The following is a description of a gene set: Human Gene Set: GSE13484_12H_VS_3H_YF17D_VACCINE_STIM_PBMC_UP species: Homo sapiens from publication Querec TD, Akondy RS, Lee EK, Cao W, Nakaya HI, Teuwen D, Pirani A, Gernert K, Deng J, Marzolf B, Kennedy K, Wu H, Bennouna S, Oluoch H, Miller J, Vencio RZ, Mulligan M, Aderem A, Ahmed R, Pulendran B (PMID 19029902) Genes up-regulated in comparison of peripheral blood mononuclear cells (PBMC) cultured with YF17D vaccine for 12 h versus PBMC cultured for 3 h. The immune responses generated by YF-17D by profiling genes in PBMCs from 2 donors cultured with YF-17D vaccine were accessed after 3 and 12 hours., and this is the list of marker genes: CCL8, IFI44L (NCBI Gene Id 10964, interferon induced protein 44 like), LSM6, LHFPL2, XYLT1, TRAPPC3, TPP1, ZBTB14, SELENOT, ATP5F1E, HTRA2, MYO1F, SOS1, MAVS (mitochondrial antiviral signaling protein), TMEM187, LYST, ANP32B, RASSF4, LGALS3, CPM, MEGF9, LIMK2, MYO1B, ZFPL1, LRP12, CYBC1, KIF1B, WDR12, CALCRL, CERS2, PLAT, TGFA, NSD2, ACSM3, SLC46A3, TBC1D2, CHCHD3, ADPRH, ZNF529, RCBTB2 (NCBI Gene Id 1102), NCOA4, OAZ2, AP1AR, IDH1, TRMT2A, UTP14C, CDC42EP2, AKR1B1, COIL, PPP1R3D, GRIA2 (NCBI Gene Id 2891), DCUN1D4, RSRP1, BSCL2, ATRX, RIDA, ZNF280D, SEC22B, SNRNP25, GFOD3P, RENBP, PAPSS1, ADAP2, PGS1, POLG2, BORA, SERPINB7 (NCBI Gene Id 8710), CRIPT, DNMT1, MGLL (NCBI Gene Id 152009), DCLK1, PCSK1N, HSD11B1, CEP192, RNASEH2B, NLRX1, FDFT1, KDELR2, VAMP1, AGPAT1, PIP4K2C, LCK, KIAA0408, FABP5, RAB20, SNRNP70, ABCA5, KTN1, SLC19A2, NUCKS1, CBFA2T2 (CBFA2/RUNX1 partner transcriptional co-repressor 2), CHFR, SMAP1, PFKM, H1-0, CCR5, CCDC22, CRIM1, BTN3A1, CTSH, B3GAT3, POLR2D, CASP5, PSMD4, RESF1, ERBIN, STMN3, LMO3, P3H1, SEZ6L, SYNC, MCM9, KLHL12, THEMIS2, MAPK1, CDKN2AIP, METTL13, ACOT8, ZMIZ2, SMAD5, SIGLEC9, UBE2V2, ATP5PF, ARL15, THYN1, AUH, DENND1C, ERG28, MPZL1, STX7, ZDHHC6, RBM6, BBS4, MET, ARPC1B, ATP8B4, CCL17, AGRN (agrin), MICU1, ATP6V0C, C1orf50 (NCBI Gene Id 79078), MAP3K12, RNASEH2A, PHTF2, BCCIP (NCBI Gene Id 56647), AASDHPPT, LPP, DPP8, PUS1, ABI1, ACYP1, METTL3, RAB28, CNTRL, ELOA-AS1, THADA, SPG21, TNKS, HDHD5, TMC5, ZNF274, LYSET, SEPTIN9, HSD17B4, HACD1, NAE1, ABCC2, THBS1, VPS13B (NCBI Gene Id 54990), DYNLL1, CKS1B, SUCLG2, PLAGL2, FLCN, GIMAP6, FTH1, CETN3, CLOCK, LILRB1, PMS2P1, NDUFAB1, DET1, SNX11, SNX19, GGT1, GPR88, GNPDA1, RIOX2, DHRS1, TP53TG1, ATXN7L3B, PPP2R5E (protein phosphatase 2 regulatory subunit B'epsilon), MSRB1, LASP1, PRDX1, IP6K1, ADO, ENTR1, FAM110B, IL10RB